The following is a description of a gene set: Combining with a MHC class I protein complex to mediate signaling that inhibits activation of a lymphocyte. studied in species Homo sapiens Human Gene Set: GOMF_INHIBITORY_MHC_CLASS_I_RECEPTOR_ACTIVITY, and this is the list of marker genes: LILRB4, LILRA6, LILRA1, LILRB1, LILRA3, LILRB2, KIR3DL1 (NCBI Gene Id 439925), LILRB3, KIR2DS5, LILRA5, LILRA2, LILRA4, LILRB5